The following is a description of a gene set: Human Gene Set: GOMF_ACETYLGLUCOSAMINYLTRANSFERASE_ACTIVITY studied in species Homo sapiens Catalysis of the transfer of an N-acetylglucosaminyl residue from UDP-N-acetyl-glucosamine to a sugar., and this is the list of marker genes: RFNG, HEXA, EOGT, B3GNT3, LFNG, POMGNT2 (NCBI Gene Id 84892), GCNT3, LARGE1, PIGQ, EXTL2, EXT2, A4GNT, MGAT4B, HEXB, MGAT4C, MGAT1, B3GNT2, B3GLCT, MGAT5, MGAT5B (alpha-1,6-mannosylglycoprotein 6-beta-N-acetylglucosaminyltransferase B), GCNT4, PIGY, B4GAT1 (beta-1,4-glucuronyltransferase 1), MGAT2 (alpha-1,6-mannosyl-glycoprotein 2-beta-N-acetylglucosaminyltransferase), PIGA, MGAT3, ALG13, EXT1, EXTL1, MFNG, EXTL3, GCNT1, MGAT4A, GCNT7, B3GNT6, B3GNT4, GCNT2, PIGP, MGAT4D, B3GNT7, B3GNT5, B3GNT8, POMGNT1, OGT